Given this list of marker genes ZFAND6, PIPOX, HACL1, HAO2, GSTK1, HMGCL, MPV17, IDH1, PECR, PEX5, NOS2, SLC27A2, USP9X, ACOT2, PHYH, ACOX3, CAT, PEX6, DECR2, MLYCD, ACOT8, PEX7, AGPS, CRAT, PEX1, GNPAT, HAO1, NUDT19, ACOT4, ECI2, AMACR, DDO, ACOX1, PEX2, ACOX2, EHHADH, LONP2, PAOX, DHRS4, UBC, DAO, RPS27A, ACAA1, UBA52, AGXT, PEX12, EPHX2, IDE, UBE2D2, ECH1, SCP2, PEX13, PEX14, HSD17B4, UBE2D1, UBB, TYSND1, CROT, BAAT, PEX26, NUDT7, UBE2D3, PEX10 (peroxisomal biogenesis factor 10), here is a description of the gene set: Peroxisomes are small cellular organelles that are bounded by a single membrane and contain variable compositions of proteins depending on cell type. Peroxisomes function in oxidation of fatty acids, detoxification of glyoxylate, and synthesis of plasmalogens, glycerophospholipids containing an alcohol with a vinyl-ether bond. All of the approximately 46 proteins contained in peroxisomal matrix are imported from the cytosol by a unique mechanism that does not require the imported proteins to be unfolded as they cross the membrane. The incompletely characterized process appears to involve the transport of the proteins through a variably sized pore in the membrane comprising at least PEX5 and PEX14 (inferred from the yeast homologs in Meinecke et al. 2010, the yeast pore is reviewed in Meinecke et al. 2016). Oligomeric proteins are also observed to cross the peroxisomal membrane but their transport appears to be less efficient than monomeric proteins.<br>In the cytosol, receptor proteins, PEX5 and PEX7, bind to specific sequence motifs in cargo proteins. The long and short isoforms of PEX5 (PEX5L and PEX5S) bind peroxisome targeting sequence 1 (PTS1, originally identified in firefly luciferase by Gould et al. 1989) found on most peroxisomal matrix proteins; PEX7 binds PTS2 (originally identified in rat 3-ketoacyl-CoA thiolase by Swinkels et al. 1991) found on 3 imported proteins thus far in humans. The long isoform of PEX5, PEX5L, then binds the PEX7:cargo protein complex. PEX5S,L bound to a cargo protein or PEX5L bound to PEX7:cargo protein then interacts with a complex comprising PEX13, PEX14, PEX2, PEX10, and PEX12 at the peroxisomal membrane.<br>The ensuing step in which the cargo protein is translocated across the membrane is not completely understood. During translocation, PEX5 and PEX7 become inserted into the membrane and expose a portion of their polypeptide chains to the organellar matrix. One current model envisages PEX5 as a plunger that inserts into a transmembrane barrel formed by PEX14, PEX13, PEX2, PEX10, and PEX12 (the Docking-Translocation Module).<br>After delivering cargo to the matrix, PEX5 and PEX7 are recycled back to the cytosol by a process requiring mono-ubiquitination of PEX5 and ATP hydrolysis. PEX7 is not ubiquitinated but its recycling requires PEX5 mono-ubiquitination. A subcomplex of the Docking-Translocation Module comprising the RING-finger proteins PEX2, PEX10, and PEX12 conjugates a single ubiquitin to a cysteine residue of PEX5. The mono-ubiquitinated PEX5 and associated PEX7 are then extracted by the exportomer complex consisting of PEX1, PEX6, PEX26, and ZFAND6 (inferred from rat homologs in Miyata et al. 2012). PEX1 and PEX6 are members of the ATPases Associated with diverse cellular Activities (AAA) family, a group of proteins that use the energy of ATP hydrolysis to remodel molecular complexes. PEX1 and PEX6 form a hetero-hexameric ring, best described as a trimer of PEX1/PEX6 dimers (inferred from yeast in Platta et al. 2005, yeast homologs reviewed in Schwerter et al. 2017). Data on the yeast PEX1:PEX6 complex suggest that these ATPases use a substrate-threading mechanism to disrupt protein-protein interactions. PEX7 is also then returned to the cytosol. Once in the cytosol, ubiquitinated PEX5 is enzymatically deubiquitinated by USP9X and may also be non-enzymatically deubiquitinated by nucleophilic attack of the thioester bond between ubiquitin and the cysteine residue of PEX5 by small metabolites such as glutathione.<br>Defects in peroxisomal import cause human diseases: Zellweger syndrome, neonatal adrenoleukodystrophy, infantile Refsum disease and rhizomelic chondrodysplasia punctata types 1 and 5. species: Homo sapiens part of: Protein localization Reactome Pathway: Peroxisomal protein import